Given this list of marker genes Lgals3, Vwf, Fcgr4, Gria1, Cd300lg, Lilra6, Fcer2a, Fcer1g, Pira2, Fcgr1, Fcgr2b, Pigr, Pira12, Jchain, Hrg, Gria2 (glutamate receptor, ionotropic, AMPA2 (alpha 2)), Fcgr3, Fcamr, Cd4, Pip (prolactin induced protein), Pira13, Umod, Ambp, Fcgrt, Ms4a2, Fcer1a, Fcmr, Ms4a1, here is a description of the gene set: species: Mus musculus Mouse Gene Set: GOMF_IMMUNOGLOBULIN_BINDING Binding to an immunoglobulin.